Given this list of marker genes Slc2a5 (NCBI Gene Id 56485), here is a description of the gene set: electronically inferred by orthology from the curated human pathway This event has been computationally inferred from an event that has been demonstrated in another species.<p>The inference is based on the homology mapping from PANTHER. Briefly, reactions for which all involved PhysicalEntities (in input, output and catalyst) have a mapped orthologue/paralogue (for complexes at least 75% of components must have a mapping) are inferred to the other species. Reactome Pathway: Intestinal hexose absorption species: Mus musculus part of: Intestinal absorption